Given this list of marker genes STK11, MSH3, ENG, TREX1, BMPR1A, SMAD4, APC, here is a description of the gene set: species: Homo sapiens Human Gene Set: HP_MULTIPLE_GASTRIC_POLYPS Multiple gastric polyps